The following is a description of a gene set: Genes up-regulated in KLRG1- T reg:SELL high CD69- versus SELL low CD69+. Human Gene Set: GSE36527_CD62L_HIGH_CD69_NEG_VS_CD62L_LOW_CD69_POS_TREG_KLRG1_NEG_UP studied in species Homo sapiens Thymic-derived natural T regulatory cells (nTregs) are characterized by functional and phenotypic heterogeneity. Recently, a small fraction of peripheral Tregs have been shown to express Klrg1, but it remains unclear the extent Klrg1 defines a unique Treg subset. Here we show that Klrg1+ Tregs represent a terminally differentiated Treg subset derived from Klrg1- Tregs. This subset is a recent antigen-responsive and a highly activated short-lived Treg population that expresses enhanced levels of Treg suppressive molecules and that preferentially resides within mucosal tissues. The development of Klrg1+ Tregs also requires extensive IL-2R signaling. This activity represents a distinct function for IL-2, independent from its contribution to Treg homeostasis and competitive fitness. These and other properties are analogous to terminally differentiated short-lived CD8+ T effector cells. Our findings suggest that an important pathway driving antigen-activated conventional T lymphocytes also operates for Tregs. Gene expression analysis was performed of this and other Treg subsets based on expression of CD62L, CD69, and Klrg1 to define the molecular properties of Klrg1+ Tregs and its relationship to other Treg subsets found in the peripheral immune tissues. from publication Cheng G, Yuan X, Tsai MS, Podack ER, Yu A, Malek TR (PMID 22786769), and this is the list of marker genes: PTGR3, CD320, SMTNL1, GRB10, RBMX, DNAAF5, WASF2, RASGRP2, ERF, GPAM, RXFP2, DNAJA3, MMD, ZDHHC16, HMGCR, IRX2, CYP1B1, RPA1, MKNK2, RAMP3, GEMIN6, OSR1, ZDHHC9, KDM2B, PFKFB1, CEP15, METTL27, TTC17, SH2D3C, PALMD, PLIN5, CD27, CLDN2, ZNF841, SKP2, GYPC, ADPRM, ALKBH4, CERS4, APPL2, EOMES, ZNF830, USP1, OTX2, TCAF2, ZMYM3, SIAH1, TDRP, RAB4A, KAT7, DMGDH, RAD1, THTPA, CAPN15, CD28, MUC15, POLG2, TFB1M, SIRT7, SLC46A3, RPS6KB2, PLCE1, GMIP (NCBI Gene Id 51291), MCM7, RAI14 (NCBI Gene Id 79367), CALU, FAM118A, HMGA2, ATP6V0A2, DBF4, MKRN2, OBP2B, NOTCH4, ARHGEF10L, CREB1, MFSD8, RNF7, PDXDC1, RPL27, NPRL2, SLC25A51, MMP14, ARL4D, PRRT1, ZYG11B, IP6K1, MYB, CCNC, BOLL, PDE9A, HOXD1, KLF3, CA3, MTFR1, SGPL1, SLC10A6, TFG, GREM2, KCNA6, TMEM98, TXNIP, DUSP10, PRG2, DICER1, HYAL2, IL36RN, PKIA, MSH4 (NCBI Gene Id 4438), RHPN2, MBP, RBBP9, OGA, ATP6V1D, TUBB2A, CALCB, MTCH2, AIM2, NKAP, SLC4A1, CCR7, GMFB, SSX2IP (SSX family member 2 interacting protein), PSCA, POF1B, TRPT1 (NCBI Gene Id 93089), HAUS5, SASH3, PLEKHS1, DCTN4, EPB41L5, RAB3IP (NCBI Gene Id 64325), TERF1, ENTPD4, HDAC2, RPL9, EXOSC10, FHL5, GPHA2, FMOD, PAPSS1, SLC25A28, CRBN, ATP1B2, VPS26C (NCBI Gene Id 10311), HILPDA (NCBI Gene Id 92496), CFAP95, CENPT, NEU1, ADGRG3, CBFB, MFNG, FSCN3, CYP2A6, PRUNE1, ZNF354C, NCK1 (NCBI Gene Id 4690), SLC12A3, SS18, SCFD1, B4GALT1, ADRB1, TMEM60, RGS10, EMD, C8G, NIT1, SRD5A2, FZD4, MBTPS1, TMEM199, IPO8, INPP5E, TIPRL, SLC28A2, IARS2, NPPA, RAMAC, TPRG1L, ENO3, NIF3L1, UBE2V2, NUP37, PLXDC2, SRGAP3, RPE, CPT1A, MAPK14, LACTB2, SMAD7, IL1RAP, IL16, SARAF, ZFP36L2, RAD51B, CENPQ, SLC20A1, BMP15, DNAJA2 (NCBI Gene Id 9237), PUS10 (NCBI Gene Id 150962)